Given this list of marker genes Tbxas1, Rhoa, Chrm3 (NCBI Gene Id 12671), Fgb, Htr2c, Adra2c, Ptger3, Hrh1, Dbh, Ptgs1, Pdgfb, Alox5, Uts2r, Cd38, Rbfox2, Adra1d, Wdr35, Avpr1a, Grk2, F2r, Oxtr, Smad6, Avpr2, Casr, Ace, Add3, Cysltr1 (NCBI Gene Id 58861), Cav1, Hmgcr, Faah, Icam1, Avp, Ptgs2, Mgll, Tbxa2r, Hrh2, Trpm4, Akt1, Tacr1, Gja1, Shc1, Fga, Npy1r, Abl1, Egfr, Htr2a, Smtnl1, Fgg, Avpr1b, Gja5, Chga, Adra1a, Pde5a, here is a description of the gene set: species: Mus musculus Mouse Gene Set: GOBP_POSITIVE_REGULATION_OF_VASOCONSTRICTION Any process that activates or increases the frequency, rate or extent of vasoconstriction.